Given this list of marker genes Stat6, Hnrnpd, Aqp1, Bcar1, Kcnc2, Map3k5, Gata5 (GATA binding protein 5), Traf2, Dpep1, Mapk8 (mitogen-activated protein kinase 8), Gucy1b1, Thbs1, Aifm1, Ccna2, Mtr, Cflar, Atp5f1a, Foxo1, Crk, Ptpn1, here is a description of the gene set: species: Mus musculus Any process that results in a change in state or activity of a cell (in terms of movement, secretion, enzyme production, gene expression, etc.) as a result of a reactive nitrogen species stimulus. Mouse Gene Set: GOBP_CELLULAR_RESPONSE_TO_REACTIVE_NITROGEN_SPECIES